The following is a description of a gene set: Xeroderma pigmentosum (XP) and trichothiodystrophy (TTD) syndromes are characterized by deficiency in nucleotide excision repair pathway, but with distinguished clinical manifestations. While XP patients exhibit a high frequency of skin cancer, TTD patients are not cancer prone. The relation between lack of DNA repair and their clinical manifestations was investigated through analysis of the transcriptional profile of 12,600 transcripts in two isogenic cell lines with different capabilities of DNA repair. These cell lines result from a stable transfection of the XPB-TTD allele into XP complementation group B fibroblasts, from an XP patient who also have clinical abnormalities corresponding to Cockayne's syndrome (CS). The microarray assays performed under normal growth conditions showed the expression of distinct groups of genes in each cell line. The UVC-transcription modulation of these cells revealed the changes in 869 transcripts. Some of these transcripts had similar modulation pattern in both cells, although with eventually different time patterns for induction or repression. However, some different 'UVC signature' for each cell line was also found, that is, transcripts that were specifically UV regulated depending on the DNA repair status of the cell. These results provide a detailed portrait of expression profiles that may potentially unravel the causes of the different phenotypes of XP/CS and TTD patients. from publication da Costa RM, Riou L, Paquola A, Menck CF, Sarasin A (PMID 15608684) studied in species Homo sapiens Human Gene Set: DACOSTA_UV_RESPONSE_VIA_ERCC3_TTD_UP Genes exclusively up-regulated in fibroblasts expressing the TTD mutant form of ERCC3, after UVC irradiation., and this is the list of marker genes: HOXD9, MPDU1, THBS1, UBL4A, TRIM25, ARPC4, PLD3 (phospholipase D family member 3), GNL1, SMARCD2, RPUSD2, UBA1 (NCBI Gene Id 8247), KISS1 (KiSS-1 metastasis suppressor), MYBL2, STK25, AAMP, FKBP2, FLNA, EPOR, COX6A1, CDKN2B, AMACR (NCBI Gene Id 23600), PVR, MRPS12, BSG (basigin (Ok blood group)), BAD, ADO, STAT1, MRPL28, PGF, GCH1, CDK16, GALK1, MVD, PCDH9, CALR, BUD23, CBX2, ADD1, SAT1, TLE5 (TLE family member 5, transcriptional modulator), BAK1, CBX4, GLS, STX16, ERCC2, CAVIN1, GALNT2, EPHX1, PDAP1, GET3, TRIM21, PPIF (peptidylprolyl isomerase F), PDLIM7, PLCB3, MDK, TNFSF13, ERBB2, PLXNA3, IGFBP6